The following is a description of a gene set: Human Gene Set: GSE37416_CTRL_VS_6H_F_TULARENSIS_LVS_NEUTROPHIL_UP We demonstrated recently that both constitutive and FAS-triggered apoptosis of human neutrophils are profoundly impaired by Francisella tularensis, but how this is achieved is largely unknown. To test the hypothesis that changes in neutrophil gene expression contribute to this phenotype, we used human oligonucleotide microarrays to identify differentially regulated genes in cells infected with F. tularensis strain LVS compared with uninfected controls. In order to examine the effect of F. tularensis on the neutrophil transcriptome, we performed microarray expression analysis on human neutrophils treated with F. tularensis subsp. holarctica live vaccine strain (LVS). from publication Schwartz JT, Bandyopadhyay S, Kobayashi SD, McCracken J, Whitney AR, Deleo FR, Allen LA (PMID 22986450) Genes up-regulated in comparison of control polymorphonuclear leukocytes (PMN) at 6 h versus PMN treated with F. tularensis vaccine at 6 h. species: Homo sapiens, and this is the list of marker genes: APPL2, PDLIM2, RESF1, CHST14, TMEM243, ABCC5, IDH1, ZNF688, SDC2, TOP3A, RASGEF1A, HSPA8, SUCNR1, SLC40A1, AMN1, MPPE1, DEF8, ZMPSTE24, NSFL1C, MSRB2, LIX1L, TWF2, HHEX, SDE2, MRPL58, VPS54, ME2, TAPT1-AS1, NDC80, NCKAP1L, ABHD2, ELP1, NDUFA2, MTURN, HERC1, XPO7, MED25, KIF21B, RPS16P5, TSPYL4, RFC3, FAM91A1, ST3GAL6 (ST3 beta-galactoside alpha-2,3-sialyltransferase 6), IMPA2, LIMD2, GSK3B, FAM174A, H2BC10, HDAC1, KIAA0232, SPIDR, DDX28, FUNDC1, NAA10, PDE3B, NT5C, KLHL7, ZNF75D, SLC19A1, RFC2, TGFBR2, C5AR2, UBN1, PKN2, STK4, RPGRIP1, CASP2, TACC1, ZMAT2, SLC25A20, NUDT3, PRPF38B, RGS18, DSTYK, LNX2, RNF114, FAM43A, KIAA0040, EED, ZNF518B, LRP10, ADGRE2, JPX, ISL2, TLR1, RABIF, MLXIP, ARHGAP19, TLR6, SLF1, ZC3H13, SLC38A2, ICAM3, UGGT1, FAM78A, INPP5B, GALNT1, TMEM219, MSL3, CARD6, PTRH2 (peptidyl-tRNA hydrolase 2), NCBP2AS2, BICD2, GTF3C1, DPEP2, NCK1, GLRX2, FAM13B, TAX1BP3, SGPP1, MAP7, TBC1D14, FKRP, ATG2B, PGD, NFATC3 (nuclear factor of activated T cells 3), CEP44, LAMP2 (NCBI Gene Id 3920), RFK, XYLT1, CD46, GRAMD1C, MIR21, RPS6KB2, BCAP31, RFLNB, RASSF1, SERINC5 (serine incorporator 5), DPY30, HVCN1, BRI3BP, CEP43, FIG4, ATP6V0B, MTM1, ABHD3, GSEC (G-quadruplex forming sequence containing lncRNA), MPZL1, ATP6AP2, CEBPD, TCP11L2, TIGD1, PIP4P2, KCTD12, RAB37, GABPB1-IT1, CUL4B, MBIP, KCNE3 (NCBI Gene Id 10008), CHMP1B, CTBS, HEATR5A, CMTM4, UBE4B, EVI2A, MIR646HG, CBX3P2, SLC25A44, EXTL3, KIAA0930, PRDX3, ITGAE, SLC16A5, DHRS9, LCLAT1, CCNY, CASP3, TIGD3, DUS2, MTMR12, SLC22A15, RABAC1, KLHDC2, FAM53B, CNOT6, GNB4 (NCBI Gene Id 59345), NLRP12, CHUK, CALHM6, SLMAP, ZNF516, EPRS1, DGCR2, GPR27, TCHP, SLC25A3, NDUFB1, AIDA, GSKIP, HNRNPUL1, G6PD, MPC2, DHTKD1, MAVS, FDFT1, MAP3K3